The following is a description of a gene set: Mouse Gene Set: GOBP_DETECTION_OF_LIGHT_STIMULUS_INVOLVED_IN_SENSORY_PERCEPTION species: Mus musculus The series of events in which a light stimulus is received by a cell and converted into a molecular signal as part of the sensory perception of light., and this is the list of marker genes: Cacna1f, Rbp4, Tulp1, Crb1, Gnat1, Gja10, Cep250, Gnat2 (G protein subunit alpha transducin 2), Gnat3, Ccdc66, Grm6, Best1, Reep6, Rgs9bp, Atp8a2, Pcare, Rpe65, Gucy2f, Rom1, Cacnb4, Sema5b (sema domain, seven thrombospondin repeats (type 1 and type 1-like), transmembrane domain (TM) and short cytoplasmic domain, (semaphorin) 5B), Prph2, Sema5a, Cngb1, Cacna2d4